Given this list of marker genes SLC1A3, here is a description of the gene set: species: Homo sapiens Reactome Pathway: Defective SLC1A3 causes episodic ataxia 6 (EA6) There are two classes of glutamate transporters; the excitatory amino acid transporters (EAATs) which depend on an electrochemical gradient of Na+ ions and vesicular glutamate transporters (VGLUTs) which are proton-dependent. Together, these transporters uptake and release glutamate to mediate this neurotransmitter's excitatory signal and are part of the glutamate-gluatamine cycle.<br><br>The SLC1 gene family includes five high-affinity glutamate transporters encoded by SLC1, 2, 3, 6 and 7. These transporters can mediate transport of L-Glutamate (L-Glu), L-Aspartate (L-Asp) and D-Aspartate (D-Asp) with cotransport of 3 Na+ ions and H+ and antiport of a K+ ion. This mechanism allows glutamate into cells against a concentration gradient. This is a crucial factor in the protection of neurons against glutamate excitotoxicity (the excitation of nerve cells to their death) in the CNS (Zhou & Danbolt 2014).<br><br>SLC1A3 is highly expressed in the cerebellum but also found in the frontal cortex, hippocampus and basal ganglia. Defects in SLC1A3 have been shown to cause episodic ataxia type 6 (EA6; MIM:612656) where mutations in SLC1A3 can lead to decreased glutamate uptake, thus contributing to neuronal hyperexcitability to cause seizures, hemiplegia and episodic ataxia. part of: SLC transporter disorders